Given this list of marker genes HRH2, SNX10, NMU, SLC26A7, SGK1, CHRM5, PTGER3, SLC9A4, SCT (NCBI Gene Id 6343), GHRL, CCKBR, HIP1R, KCNQ1, TFF2, here is a description of the gene set: Human Gene Set: GOBP_GASTRIC_ACID_SECRETION studied in species Homo sapiens The regulated release of gastric acid (hydrochloric acid) by parietal or oxyntic cells during digestion.